The following is a description of a gene set: Any process that stops, prevents, or reduces the frequency, rate or extent of the BMP signaling pathway. Mouse Gene Set: GOBP_NEGATIVE_REGULATION_OF_BMP_SIGNALING_PATHWAY studied in species Mus musculus, and this is the list of marker genes: Tnfaip6, Lemd2, Hipk2, Grem1 (gremlin 1, DAN family BMP antagonist), Sostdc1, Tmem53 (NCBI Gene Id 76384), Notch1, Sfrp2, Dkk1, Vwc2l, Nog, Lemd3, Tmprss6, Skil (SKI-like), Vwc2, Sost, Lrp2, Erfe, Skor2, Tcf7l2, Ski, Nbl1, Htra3, Dlx1, Cer1, Ppm1a, Sfrp1, Cav1, Spart (NCBI Gene Id 99725), Pparg, Fzd1, Fstl3, Gpr155, Mtmr4, Gdf3 (NCBI Gene Id 97289), Htra1, Grem2 (NCBI Gene Id 23893), Trim33, Bmper, Tob1, Nanog, Twsg1 (twisted gastrulation BMP signaling modulator 1), Smad6, Smurf1, Fbn1, Skor1, Ctdspl2, Chrdl2, Bambi, Dand5, Rbpms2, Hjv, Abl1, Wnt5a, Smad7, Wnt1, Sorl1, Chrdl1, Chrd, Mir675, Crim1, Smurf2